The following is a description of a gene set: Human Gene Set: HP_OROMOTOR_APRAXIA Oromotor apraxia Oral-motor apraxia is the inability to volitionally sequence oral movements of the speech structure for nonspeech tasks in the absence of neuromuscular deficits such as paralysis or muscle weakness. Oral-motor apraxia is diagnosed when, despite intact sensory motor function an individual is unable to use these effector systems under voluntary control. species: Homo sapiens, and this is the list of marker genes: CDON, FGFR1, PTCH1, DLL1, SIX3, GLI2, CRIPTO, CLTC, FOXP2, FOXP1, FOXH1, DDOST, DISP1, PI4KA, SHH, STIL, NODAL, ZIC2, PLCH1, VPS11, SRPX2, TGIF1, GAS1, FGF8, ADGRG1, STAG2, SMC1A, TUBB2B